The following is a description of a gene set: studied in species Homo sapiens Human Gene Set: REACTOME_REGULATION_OF_ENDOGENOUS_RETROELEMENTS_BY_PIWI_INTERACTING_RNAS_PIRNAS Regulation of endogenous retroelements by Piwi-interacting RNAs (piRNAs), and this is the list of marker genes: RBBP4, PIWIL4, SS18L1, H2BC12, H4C8, H2AB1, GATAD2A, ACTL6A, H2BC8, H4C12, HDAC2, H2BC13, CHD4, ARID1B, H2BC17, H4C6, H3C2, GATAD2B, H3C13, H4C11, DPF1, SS18, H4C5, H2BC6, MTA2, H2AC19, H3C4, H2AJ (H2A.J histone), SMARCA2, H3-3B, H2BC12L, SMARCD1, BCL7A, SPOCD1, H2BC10, SMARCB1, SMARCE1, H3C14, SMARCC1, ARID1A, H4C3, H2AC14, HDAC1, MTA1, H3C11, ACTB, H3C12, H2AC18, MTA3, DNMT3A, BCL7B, CHD3, H3C15 (H3 clustered histone 15), H2BC14, H2BC15, H2BC7, SMARCA4, H2AC6, SMARCD3 (SWI/SNF related, matrix associated, actin dependent regulator of chromatin, subfamily d, member 3), SMARCD2, H3C3, H4C2, H3C8, H3C10, H2BC3, H2BC11, H2BC26, H4C4, H4C13, H2AX, H2BC9 (NCBI Gene Id 8345), H2BC4, H2AC4, H3-3A, H2BC1, H4C9, H3C6, H2AC8, C19orf84, DPF2, H2AC7, H4C16, H4C14, H2BC21, DPF3, H2AZ2, BCL7C, H3C7, DNMT3L, H4C1, RBBP7, H2BC5, H2AC20, MBD3, H4C15, SMARCC2, H3C1